The following is a description of a gene set: Human Gene Set: GOBP_REGULATION_OF_AXON_DIAMETER studied in species Homo sapiens Any process that modulates the rate, direction or extent of axon growth such that the correct diameter is attained and maintained., and this is the list of marker genes: NEFL, KEL, XK, WNT7A, CNTN2